Given this list of marker genes RPUSD4, FASTKD1, KANSL1, CHCHD10, TBRG4, MRPL12, TWNK, NSUN4, SLC25A33, TARS2, GARS1, EARS2, TRMT5, METTL4, KAT8, FOXO3, MTO1, MYG1, MTERF2, PRORP, CDK5RAP1, SLIRP, MTRES1, TFB1M, TEFM, PRKAA1, TRNT1, TRIT1 (NCBI Gene Id 54802), HSD17B10, POLRMT, SARS2, PNPT1, SUPV3L1, TRMT61B, DARS2, GRSF1, C1QBP, AARS2, MTERF4, KANSL3, PUS1, ELAC2, GTPBP3, PDE12 (NCBI Gene Id 201626), WARS2, TFAM, ANGEL2, TFB2M, METTL8, THAP11, LRPPRC, YARS2, TRMT10C, MTERF1, MTERF3, here is a description of the gene set: The chemical reactions and pathways involving RNA transcribed from the mitochondrial genome and occurring in the mitochondrion. species: Homo sapiens Human Gene Set: GOBP_MITOCHONDRIAL_RNA_METABOLIC_PROCESS